Given this list of marker genes B4galt1, Lhcgr, Bax, Areg, Med1, Stat5b, Tgfb1, Ncoa3, Irf2bpl, Phb2, Nell2, Stat5a, Wnt5a (wingless-type MMTV integration site family, member 5A), here is a description of the gene set: The process whose specific outcome is the progression of the secondary sexual characteristics over time, from their formation to the mature structures. In humans, these include growth of axillary, chest, and pubic hair, voice changes, testicular/penile enlargement, breast development and menstrual periods. Development occurs in response to sex hormone secretion. Mouse Gene Set: GOBP_DEVELOPMENT_OF_SECONDARY_SEXUAL_CHARACTERISTICS studied in species Mus musculus